The following is a description of a gene set: Human Gene Set: GOBP_TELOMERASE_HOLOENZYME_COMPLEX_ASSEMBLY The aggregation, arrangement and bonding together of a set of components to form a telomerase holoenzyme complex. studied in species Homo sapiens, and this is the list of marker genes: ATM, NVL, HSP90AB1, HSP90AA1, DKC1, ATR, NAF1, PTGES3